Given this list of marker genes Actr3b, Gm16288, Gm5862 (predicted gene 5862), Agbl5, Rbm33, AI839979 (expressed sequence AI839979), Gm10461, 5033423K11Rik, Speer4a2, Gm9555, Cgref1, Gm1979, Insig1, Dpp6, Dnajc5g, Eif2b4 (eukaryotic translation initiation factor 2B, subunit 4 delta), Gm9970, Gtf3c2, Kcnk3, Ost4, Ctbp1, Krtcap3, Cad, Gm18957, Gm21663, Gm6089, Yes1, Gm2213, Depdc5, 2900076G11Rik, Abhd1, 4930584F24Rik, Atraid, Spata31h-ps1, Tyms, Mir5625, Babam2 (BRISC and BRCA1 A complex member 2), Gm36840, Gm29609, Drc1, Cimip2c, 5930420M18Rik, Xrcc2, Ucn, Mpv17, Gm5552, Gm7347, Mnx1, Slc5a6, Gm21680, Hadhb, Speer4a3, Gm15469, Fam53a, Gpn1 (NCBI Gene Id 74254), Gm9903, Trim54, Gm29784, Zfp512 (NCBI Gene Id 70095), Pisd, Mir3473e, Uvssa, 4632411P08Rik, Gm20465, Gm10220 (NCBI Gene Id 434689), Ppp1cb, Prr14l, Gm24003, Slc35f6, Gm15614, Nkx1-1, Selenoi, Supt7l, Il6, Cib4, Dnajb6, 9530036O11Rik, Gm7361, Cnpy1, Lmbr1, Gm5067, Gm26608, Gm5864, Ube3c, Rnf32, Ppm1g, Htr5a, Gm9924, Khk, Gm20239, Maea, Ywhah, Gm21655, Slc30a3, Gm22656, 1700096K18Rik, Spon2, Zfp513, Garem2, Shh, Gckr, 3110082J24Rik, 5031410I06Rik, Plb1, Tcf23, Gm5129, Gm1969, Paxip1, Emilin1, Gm2420, Hadha, Fosl2, Dpysl5, Ccdc121, Gm15461, Gm2623, Gm7596, Gm21168, Gm7420, Gm10290, Rbks, Gm42964, Mapre3, Snx17 (sorting nexin 17), Cenpa, Gm43117, Gm19409, Gm9899, 4930566F21Rik, Slc4a1ap, Tmem214, Ift172, Gm4865, Adgrf3, Slc5a1, En2, Nrbp1, Gm6083, Nom1, 4930478M09Rik, Mrpl33, Gm10062, Speer4a1, Gm4961, Mir1960, Preb, Cct8l1, Speer4b, Gm16058, Fndc4, Gm10463, Gm21698, Kmt2c, Gm19457, Gm5551 (predicted gene 5551), Otof (otoferlin), Rpl35a-ps5, here is a description of the gene set: Mouse Gene Set: chr5B1 species: Mus musculus